Given this list of marker genes C1QTNF3, POLDIP3, MBNL1, BBX, HSP90AB1, KLC2, SPAG7, ZNF207, ADGRG4, UCN, HSPB7, MAP2, HDAC9, FOXQ1, ALDOA, RAB1B, TPP1, SCUBE3, NR2F1, SDC1, WIPI1, CFL2, PNKP, SORBS1, NPAS4, HMGN2, IRAK1, SHOX2, STX5, JDP2, MRGPRF, FGFRL1, CHD6, SGCG, INA, SOX12, ACTC1, EGFLAM, POU4F3, HTN1, SLCO1C1, PLPP3, ETHE1, PHKA1, RBMS1, CS, CLUH, PPP1R14C, HOXC5, TFAP2C, KDM4A, XK, BRD4, TMEM255A, PCDHAC2, NKX2-2, FLNA, DUSP5, CIART, MYOZ3, CPNE1, BNC2, DYNC1LI1, CNMD, BHLHE40, POU3F4, SLC16A6, GSTP1, SAP30L, NRAS, CNN2, GPR22, HOXD8, DLG2, CNN1, SLC4A2, TBX20, GRK6, RBFOX1, SFXN4, ANKRD10, VASP (vasodilator stimulated phosphoprotein), SMARCA2, KLF2 (NCBI Gene Id 51713), CFL1, OVOL2, NCAM1, TNP1 (transition protein 1), COL3A1 (collagen type III alpha 1 chain), FGF19, CYCS, DMPK, FGF17, SLC22A8, TBX2, RORB, OTX1, SLC41A1 (solute carrier family 41 member 1), SLC2A4, NBPF11, SALL1, ZBTB41, ATP12A, GPRASP1, HOXA10, PDE4D, STAT5B, PAX3, GJA4, ARF6, SLITRK2, SESN3, ING2, GJD2, TMEM126B, FDX2, IMPDH2, IFRD1, ETV5, LHX1, MUS81, MEIS1, HBEGF, NR2F2, SIX1, GPRIN3, CACNG2, SLCO5A1, NFIB, SIAH1, RBMS2, DLL1, SH2D1A, MYLK, ACTG2, UBE2E2, VEZF1, ERG, DCX, ZNF644, NFATC4, PI4K2B (phosphatidylinositol 4-kinase type 2 beta), FMNL3, SLC16A1, MYL9, PDLIM7, here is a description of the gene set: Comprehensive identification of all functional elements encoded in the human genome is a fundamental need in biomedical research. Here, we present a comparative analysis of the human, mouse, rat and dog genomes to create a systematic catalogue of common regulatory motifs in promoters and 3' untranslated regions (3' UTRs). The promoter analysis yields 174 candidate motifs, including most previously known transcription-factor binding sites and 105 new motifs. The 3'-UTR analysis yields 106 motifs likely to be involved in post-transcriptional regulation. Nearly one-half are associated with microRNAs (miRNAs), leading to the discovery of many new miRNA genes and their likely target genes. Our results suggest that previous estimates of the number of human miRNA genes were low, and that miRNAs regulate at least 20% of human genes. The overall results provide a systematic view of gene regulation in the human, which will be refined as additional mammalian genomes become available. Human Gene Set: WWTAAGGC_UNKNOWN species: Homo sapiens from publication Xie X, Lu J, Kulbokas EJ, Golub TR, Mootha V, Lindblad-Toh K, Lander ES, Kellis M (PMID 15735639) Genes having at least one occurrence of the highly conserved motif M127 WWTAAGGC in the regions spanning 4 kb centered on their transcription starting sites. The motif does not match any known transcription factor binding site.